Given this list of marker genes RPTOR, IL4, PRKAA2, GUCA1ANB-GUCA1A, VCP, TREM2, TMSB4X, SLC4A4, ENO1, BEND3, GUCA1A, TIGAR, IGF1, NDUFC2, PPARA, HTR2A, P2RX7, APP, INS, PRXL2C, INSR, SRC, PSEN1, PINK1, PID1, MAP2K1, KAT2B, MLST8 (MTOR associated protein, LST8 homolog), UCHL1, IFNG, MLXIPL, TAFAZZIN, GAPDHS, ARNT, PRKN, STAT3, MTOR, ZBTB20, GPD1 (glycerol-3-phosphate dehydrogenase 1), PRKAA1, ADCY10, HIF1A, here is a description of the gene set: studied in species Homo sapiens Human Gene Set: GOBP_POSITIVE_REGULATION_OF_NUCLEOTIDE_METABOLIC_PROCESS Any process that activates or increases the frequency, rate or extent of the chemical reactions and pathways involving nucleotides.